Given this list of marker genes H2BC12L, H4C8, ZNF610, H2BC26, H2BC21, ZNF534, ZNF331, H2BC1, H2AB1, ZNF224, MTA1, H2AC19, H4C15 (NCBI Gene Id 724021), MTA3, H3C13, H4C6, RBBP4, H2BC5, H3C3 (NCBI Gene Id 8352), H2AJ, H3-3B, ZNF257, ZNF354A, H2AC4, H3C8, H4C4, H2BC11, ZNF418, H2BC14, H4C14 (H4 clustered histone 14), H2BC10, H3-3A, H2AC14, ZNF93, GATAD2B, ZNF33A, ZNF778, ZNF425 (zinc finger protein 425), ZNF28, H2AC7, H3C12, H2BC17, H2BC13, HDAC1, ZNF649, ZNF708, MTA2, H3C6, H2AC18, H4C16, CBX5, H2BC6, H4C5, ZNF765, ZNF30, H4C2 (NCBI Gene Id 8366), SUMO2, ZNF324 (NCBI Gene Id 64287), ZNF317, CHD3, H3C1, ZNF519, H2BC4, H2AC6, ZNF669, H3C10, H2BC9 (NCBI Gene Id 8345), H3C2, H4C11, H3C15, ZNF141, ZNF454, RBBP7, H3C11, H2BC12, ATF7IP, H3C14, SETDB1, UBE2I, H2BC15, ZNF816, ZNF264, H4C1, ZNF547, H2BC7 (NCBI Gene Id 8343), ZNF320, H2BC3, H3C7, H4C9, GATAD2A (NCBI Gene Id 54815), H4C13, H2BC8, H4C12, HDAC2, CHD4, ZNF680, H2AX, H4C3, ZNF382, ZNF136, H2AZ2, MBD3, TRIM28, H2AC8, H2AC20, H3C4, ZNF273, here is a description of the gene set: species: Homo sapiens Regulation of endogenous retroelements by KRAB-ZFP proteins Human Gene Set: REACTOME_REGULATION_OF_ENDOGENOUS_RETROELEMENTS_BY_KRAB_ZFP_PROTEINS